Given this list of marker genes CXCR2, CXCL1, RASGEF1B, TP53INP2, OGFOD3, CHAF1B, MED13, AMPD3, ARAP3, CA4, MTMR7, RALGPS2, PHLDA1, XPNPEP1, STARD8, CXCL3, ASPRV1, RBBP9, AGRN, SLC34A1, AK8, HSD17B2, MCTP2, PYCR1, BBS2, DPP8, SAMD8, HCFC2, MUC4, PDIA2, HPF1, ADHFE1, MALSU1, ATXN1, MGST1, TMT1A, GAB1, PRPS2, MAP3K5, CD177, FGD3, SARAF, SLC2A3, NR4A1, KLF10, CCK, XRCC1, SVIL, MOCOS, HSPA5, ICMT, S100A9, TVP23B, ABCD2, SERPINB2, SMC4, ARHGAP17, FPR1, CPLX1, LTF, SELL, PIGC, ARFGEF1, PLAC8, SFXN5, MMP9 (NCBI Gene Id 4318), ANO6, GALNS, HIBCH, IL1R2, TYROBP, MIDEAS, CD84, GAMT, CTDSPL, HBEGF, TMEM120A, WDR54, TMBIM6, PLK3, CTSS, CKS2, CHI3L1, TMED10, GPAT3, NFKBIZ, ITGB3, MID1IP1, GSDME, PECAM1, ADGRG3, CD53, TASL, PCCB, ATP6V1E2, EPX, SNX24, POLR3GL, ASB4, SNX6, FOXJ1, TBC1D31, ACP3 (acid phosphatase 3), FOS, CAMP, PADI4, ABCA1, PPP1R3B, TIMP2, ABT1, LYL1, DNAJC5, SLC39A4, TMEM237, ITGA2B, COX7B2, STK10, GNA12, RSF1, CD38, PDCD5, TMED3, PDE8B, IPCEF1, CREG1, IL1A, PHF21A, IRF7, FAM20C, INHBA, VEZT, DHPS, EVI2B, JMJD6, FASTKD5, RASGRP2, G6PD, PTGER2, NFE2, NUP133, NRF1, TIPARP, FAM162A (NCBI Gene Id 26355), ELL (NCBI Gene Id 84205), OSM, RHBDF1, CKLF, CENPI, DNAJB4, CD44, RTEL1, FNIP2, TCEA2, LRRC20, ADSL, PIGV, ARSB, MRPL37, MMP8, ICA1, SGK1, GNPAT, GPATCH8, CSF1, KIF3A, ARHGAP25, PPP1R21, CLEC1B, LCN2, PTGS2, RAB37, SPP1, ABCG2, SIPA1L1, HPN, BRD8 (NCBI Gene Id 10902), DHRS7, PDHB, PTER, NUDT7, ENTPD1, CWC22, RSPH3, MAGI3 (NCBI Gene Id 57725), NPRL2, PDE2A, CYB5R4, NT5E, MARCO, PLPP3, MSRA, PELO, H3C4, EGR1, MTUS1, MIPEP, UPP1, S100A8, TM7SF3, here is a description of the gene set: species: Homo sapiens from publication Gattinoni L, Lugli E, Ji Y, Pos Z, Paulos CM, Quigley MF, Almeida JR, Gostick E, Yu Z, Carpenito C, Wang E, Douek DC, Price DA, June CH, Marincola FM, Roederer M, Restifo NP (PMID 21926977) Human Gene Set: GSE23321_CENTRAL_MEMORY_VS_NAIVE_CD8_TCELL_UP An early-differentiated CD8+ memory T cell subset with stem cell-like properties (TSCM) can be identified within the naïve-like T cell population by the expression of CD95/Fas. Based on experiments including exon- and gene-level expression analysis, we provide evidence that this subset of antigen-specific cells represents an early precursor of conventional central (TCM) and effector (TEM) memory CD8+ T cells with enhanced self-renewal capacity and proliferative potential. We identified genes differentially expressed between major T cell subsets defined along with memory T cell commitment. Based on the analysis of these genes, CD95+ naïve T cells (TSCM) cluster closer to the CD8+ T memory compartment than to classical (CD95-) naïve T (TN) cells, and display an intermittent phenotype between classical TN and TCM cells in terms of all major T cell differentiation markers analyzed. Genes up-regulated in CD8 T cells: central memory versus naïve.